Given this list of marker genes Sirt1 (NCBI Gene Id 93759), Pde4d, Adm, Trpm4, Ryr2, Scn3b, Smtn, Ptger3, Atp1a1, Ccn2, Nkx2-5, Hey2, Edn1, Hrc, Atp5pf, Apela, Kcnq1, Nmu, Gsk3a, Rgs4, Ghrl, Adrb2, Adm2 (adrenomedullin 2), Edn3, Tpm1, Edn2, Crhr2, Scn5a, Dusp5, Avpr1a, Adra1b, Adra1a, Adrb1, Apln, Chrna7, Slc1a1, Tgfb2, Ptpn1, Ptger2, Ada, Tacr3, Hsp90aa1, Ace2, Nppa, Rgs2, Uts2, Gch1, Chga, Ucn, here is a description of the gene set: Mouse Gene Set: GOBP_POSITIVE_REGULATION_OF_BLOOD_CIRCULATION Any process that activates or increases the frequency, rate or extent of blood circulation. studied in species Mus musculus